Given this list of marker genes CCDC134, GATM, SLC34A1, OBSCN, HRAS, INPPL1 (NCBI Gene Id 3636), SOX5, ABCC6, CYP3A4, CYP27B1, ENPP1, PHEX, SLC34A2, MIR140, CTNS, CLDN16, DMP1, POLRMT, EHHADH, GNA11, NRAS, SAMD9, CACNA1S, GCM2, KCNJ18, ZEB2, STX16, GALNT3, MEN1, TNFRSF11B, OCRL, CLCN5, HMGCS2, GNAS, LPIN1, KRAS, GABRA3, CASR, MT-CO1, NDUFAF6, BRAF, RAF1, SLC2A2, AP2S1, RYR1, PRKAR1A, COL4A3, PTH, CMPK2 (cytidine/uridine monophosphate kinase 2), FGF23, SNX10, FAM20C, ALDOB, ALPL, TRPS1, PTH1R, TBCE, CDC73, ALK, CYP2R1, SLC34A3 (solute carrier family 34 member 3), FAH, VDR (NCBI Gene Id 7421), FAM111A, HNF4A, TNFSF11, KL, NAB2, GNAS-AS1, NHERF1, MT-CO3 (NCBI Gene Id 4514), STAT6, CLCN7, TCIRG1, ANKH, here is a description of the gene set: Human Gene Set: HP_ABNORMAL_BLOOD_PHOSPHATE_CONCENTRATION Abnormal blood phosphate concentration studied in species Homo sapiens An abnormality of phosphate homeostasis or concentration in the body.